The following is a description of a gene set: Mouse Gene Set: CUI_LANGERHANS_IL36A_RESPONSE_UP Genes positively differentially expressed in cell type: Langerhans upon treatment with cytokine: IL-36α in mouse lymph nodes in vivo. Cytokines mediate cell-cell communication in the immune system and represent important therapeutic targets. A myriad of studies have highlighted their central role in immune function, yet we lack a global view of the cellular responses of each immune cell type to each cytokine. To address this gap, the authors created the Immune Dictionary, a compendium of single-cell transcriptomic profiles of more than 17 immune cell types in response to each of 86 cytokines (>1,400 cytokine-cell type combinations) in mouse lymph nodes in vivo. A cytokine-centric view of the dictionary revealed that most cytokines induce highly cell-type-specific responses. For example, the inflammatory cytokine interleukin-1β induces distinct gene programmes in almost every cell type. A cell-type-centric view of the dictionary identified more than 66 cytokine-driven cellular polarization states across immune cell types, including previously uncharacterized states such as an interleukin-18-induced polyfunctional natural killer cell state. studied in species Mus musculus from publication Cui A, Huang T, Li S, Ma A, Pérez JL, Sander C, Keskin DB, Wu CJ, Fraenkel E, Hacohen N (PMID 38057668), and this is the list of marker genes: Bcl2l11, Rnf213, Pdlim5, Isg15 (NCBI Gene Id 53606), Cd302, Oas2, Gtpbp4, Stat1, Tmsb10, Igsf8, Gbp2, Dhx58, Samhd1, Tcf4, Pkib, Ifi47, Mif4gd (MIF4G domain containing), Tle3 (transducin-like enhancer of split 3), Cxcl9, Ppa1, Il10ra, Sft2d2, Parp12, Igtp, Ly75, Nr4a3, Sting1, Bcl7c, Plaat3, Ifitm3, Galm, Iigp1, Slfn8, Gbp5, Aida, Tcaf2, Gstp1, Batf, Glipr2, Scn3a, Gsap, Cish, Eif2ak2, Flnb, Trim30a, Irf8, Abtb2, Oasl2, Prpf31, Cd274, Dpm1, Irgm2 (NCBI Gene Id 54396)